Given this list of marker genes MAPK3, RAF1, PSMA1 (proteasome 20S subunit alpha 1), ICMT, SHOC2, AGO3, KITLG, IL3, CAMK2A, DNAJB1, MAPK4, PDGFA, PSMB5, GDNF, FOXO3, FGF5, MRAS, ZDHHC9, RASA1, IRS2, ARRB1, JAK2, PTK2, MARK3, DUSP7, RASA4, DLG1, RAP1A, SHC2, ETV4, FGF7, DUSP6, RAG1, ERBB2, FGF3 (NCBI Gene Id 2248), WDR83, IL2RB, RASAL1, NCOA3, TLN1, KIT, IL5, IL2, CSF2RA, RAP1B, JAK1, DAB2IP, PPP2R1A, KL, PSMC3, PSMA6, FYN, RAPGEF2, FGF23, RGL3, DUSP8, CDC42EP3, FGB, FGF16, SHC1, BCL2L1, ABHD17B, PSMA4, PTPN3, PSMA7, CALM1, PEBP1, MAP2K1, CUL3, FGFR3, FGF10, VWF, NEFL, XPO1, FGG, PSPN, IL17RD, NRG1, ARL2, TYK2, IQGAP1, FGF6, KSR2, GRB2, PPP2CB, TNRC6C, CDC42EP2, ARTN, NCAM1, GFRA2, SPTAN1, IGF2BP1, ACTB, IL6R, SEM1, PDGFB, ADRM1, FNTB (farnesyltransferase, CAAX box, subunit beta), SPTBN5, ITGA2B, MAPKAPK5, ACTG1, LAMTOR2, PSMC2, FGF20, PPP2R5C, SRC, AREG, IRS1, DUSP16, NRAS, PRKG2, RASGRF2, MYC, HBEGF, PDGFRA, PSMB6, IL2RG, ARRB2, PTPN11, PSMA3, HRAS, PSMD7, ABHD17A, ANGPT1, CDC14B, IL6ST, AGO2, KRAS, FGF17, ERBB3, RASAL3, SPTBN1, MET, FNTA, SHC3, EREG, UBB, PTPRA, FGFR2, SPRED1, IL2RA, FGF4, IL6, PIK3CA, PSMB2, PEA15, DLG3, BTC, FGFR4, FGF2, RALGDS, FGF8, RAC1, FRS2, PPP2CA, CDC42, DUSP5, PSMC6, EGFR (NCBI Gene Id 1956), IL3RA, RGL1, NRTN, RASGRP3, EPGN, PSMA2, TGFA, TNRC6A, PPP2R5B, SPTBN4, ARAF, DUSP9, RASGEF1A, PSMD13, PSMD1, CNKSR1, PSMD11, VCL, EGF (epidermal growth factor), MOV10, PSMC1, PPP2R5D, FLT3LG, RANBP9, FOXO1, PDGFRB, CDC42EP5, PAQR3, SYNGAP1 (synaptic Ras GTPase activating protein 1), RCE1, FGF9, SPRED3, PSMC4, ERBB4, GRIN2B, MMP2, FGF19, PPP2R5A, BRAP, MAPK12, UBA52, YWHAB, AGO1, CNKSR2, RGL2, ACTN2, LYPLA1, GOLGA7, RASA2, SPRED2, PDE6D, CAMK2B, IL5RA, RASAL2, CSK, DUSP10, DLG4, GFRA4, DUSP4, RET, RASGRF1, FN1, PAK2, USP17L2, FLT3, SOS1, KLB, PSMD6, CSF2, GRIN2D, PPP2R1B, RBX1, CDK1, MAP3K11, GFRA3 (GDNF family receptor alpha 3), PPP1CB, FGF22, APBB1IP, RASGRP4, HSPB1, RASGRP1, KALRN, PPP2R5E, NRG3, FRS3, NRG4, MMP10, PPP5C, DUSP1, FGA, PIK3CB, DUSP2, DLG2, PSMB1, CAMK2D, MAPK6 (NCBI Gene Id 5597), MIR34C, NF1, ITGB3, CAMK2G, TEK, ABHD17C, PSMB3, FGF18, PAK3, UBC, GFRA1, PPP1CC, RAG2, PAK1, LAMTOR3, FGF1, PRKACA, MAP2K2, PRKCQ, SPTA1, PRKACG, LRRC7, BRAF, MIR34B, PSMD12, PIK3R1, PHB1, RPS27A, AGO4, RASA3, MAPK1, JUN, PSMA5, KBTBD7, FGFR1, KSR1, CSF2RB, PSMD3, PSMB4, GRIN1, SEPTIN7, CCND3, PSMB7, PIK3R2, PTPN7, JAK3, PSMC5 (proteasome 26S subunit, ATPase 5), PRKACB, SPTBN2, HGF, PSMD8, NRG2, CDC14A, PSMD2, PSMD14, TNRC6B, SPTB, LAT, here is a description of the gene set: part of: Signal Transduction studied in species Homo sapiens The mitogen activated protein kinases (MAPKs) are a family of conserved protein serine threonine kinases that respond to varied extracellular stimuli to activate intracellular processes including gene expression, metabolism, proliferation, differentiation and apoptosis, among others. <br> The classic MAPK cascades, including the ERK1/2 pathway, the p38 MAPK pathway, the JNK pathway and the ERK5 pathway are characterized by three tiers of sequentially acting, activating kinases. The MAPK kinase kinase kinase (MAPKKK), at the top of the cascade, is phosphorylated on serine and threonine residues in response to external stimuli; this phosphorylation often occurs in the context of an interaction between the MAPKKK protein and a member of the RAS/RHO family of small GTP-binding proteins. Activated MAPKKK proteins in turn phosphorylate the dual-specificity MAPK kinase proteins (MAPKK), which ultimately phosphorylate the MAPK proteins in a conserved Thr-X-Tyr motif in the activation loop.<br> Less is known about the activation of the atypical families of MAPKs, which include the ERK3/4 signaling cascade, the ERK7 cascade and the NLK cascade. Although the details are not fully worked out, these MAPK proteins don't appear to be phosphorylated downstream of a 3-tiered kinase system as described above. <br> Both conventional and atypical MAPKs are proline-directed serine threonine kinases and, once activated, phosphorylate substrates in the consensus P-X-S/T-P site. Both cytosolic and nuclear targets of MAPK proteins have been identified and upon stimulation, a proportion of the phosphorylated MAPKs relocalize from the cytoplasm to the nucleus. In some cases, nuclear translocation may be accompanied by dimerization, although the relationship between these two events is not fully elaborated. Reactome Pathway: MAPK family signaling cascades